The following is a description of a gene set: Mouse Gene Set: GOCC_LATERAL_ELEMENT A proteinaceous core found between sister chromatids during meiotic prophase. studied in species Mus musculus, and this is the list of marker genes: Rec8, Dmc1, Blm, Smc1b, Rad21l, Brca2, Smc1a, Mei4, Sycp3, Incenp, Rad51, Sycp1, Brca1, Sycp2, Smc3, Stag3, Sycp2l, Rpa1 (replication protein A1), Kash5